The following is a description of a gene set: Mouse Gene Set: chr4C3 species: Mus musculus, and this is the list of marker genes: Psip1, Frmd3, C630043F03Rik, Gm25836, Gm11266, Gm24884, Gm25653, Msantd5f2, Gm11407, Gm11263, Gm11254, Gm11259, Gm11184, Cbx3-ps3, Gm11242, Gm5287, Gm25899, Gm11243, Gm11241, Gm11260, Aldoart1, Msantd5f9, Msantd5f8, Gm11257, Rasef, Gm11264, Gm10154, Gm12912, Gm5860, Msantd5f7, Msantd5f1, Ptprd, 2310002L09Rik, Gm11411, Gm25803 (predicted gene, 25803), Gm11486, B230208B08Rik, Gm11760, Gm11245, Kdm4c, Msantd5f10, Msantd5f5, Gm11415, Msantd5f3, Gm11185, Dmac1, Snapc3 (small nuclear RNA activating complex, polypeptide 3), Zdhhc21, Cer1, Ttc39b, Frem1 (NCBI Gene Id 329873), Gm11240, Tle1, Gm24170, Gm11413, Gm11405, Msantd5f4 (NCBI Gene Id 100862015), Lurap1l, Csnk2a1-ps4 (casein kinase 2, alpha 1 polypeptide, pseudogene 4), Gm11488, Gm11267 (predicted gene 11267), Gm11410, Mpdz, Gm11412, Gm11258, Gm26379, Gm25769, Msantd5f6, A230083N12Rik, Gm11269, Nfib, Gm42303, Gm11485, Ccdc171, Gm11765, Gm11251, Tyrp1, Gm11256